The following is a description of a gene set: Distal sensory impairment An abnormal reduction in sensation in the distal portions of the extremities. Human Gene Set: HP_DISTAL_SENSORY_IMPAIRMENT studied in species Homo sapiens, and this is the list of marker genes: KLHL9 (NCBI Gene Id 55958), PNPT1, POLG, HINT1, PIK3R5, CAPN1, GJB1 (gap junction protein beta 1), GBE1, CCT5, FBLN5, MTRFR, MFN2, SOX10, ABCD1, TFG, RAI1, FGD4, PLEKHG5, TRPV4, REEP1, DDHD1, APTX, XRCC1, ALDH4A1, SCN10A, LITAF, VCP, MYH14, AARS1, SPTLC2, DCAF8, TWNK, ABHD12, SAMD9L, FIG4, RNF170, YARS1, MATR3, JPH1, COX6A1, LMNB1, KIF1A, ATXN1, MSTO1, NEFL, TK2, BSCL2, PNKP, PDYN, C19orf12, SCN11A, DARS2, CAV3, XPA, ATL1, SACS, HARS1, GNB4, MARS1 (NCBI Gene Id 4141), BAG3, ATP13A2, NDRG1, KIF5A, KIF1B, SLC25A46, MTMR2, CYP7B1, ITPR3 (inositol 1,4,5-trisphosphate receptor type 3), IBA57, CAV1, HSPB1, RETREG1 (reticulophagy regulator 1), SPG11, MPZ, ZFHX3, HSPB8, DHH, KARS1, DNM2 (dynamin 2), KPNA3, ATP7A, EGR2, POLR3B, CADM3, TDP1, MED25, SBF1, AIFM1, PMP22, SCYL1, MPV17, AASS, GBF1, PRPS1, TYMP, SERPINI1, SETX, MME, MCM3AP, COA7, SCN9A, NEFH, SH3TC2, NAGLU, CHCHD10, IGHMBP2, GARS1, DNAJB2, ADA2, DYNC1H1, NAGA, ATXN10, RAB7A, GJC2, GDAP1, LMNA, INF2, PEX10, LRSAM1, NTRK1, ADCY6, SLC25A19, SYT2, GAN, HK1, ATL3, PMP2, SBF2, PDK3, MORC2, RASA1, PRX, POLR3A, SPTLC1, IARS2, MTTP